The following is a description of a gene set: We have previously shown that rheumatoid factors (RF) produced by Fas-deficient autoimmune-prone mice typically bind autologous IgG2a with remarkably low affinity. Nevertheless, B cells representative of this RF population proliferate vigorously in response IgG2a/chromatin immune complexes through a mechanism dependent on the sequential engagement of the BCR and Toll-like receptor 9 (TLR9). To more precisely address the role of both receptors in this response, we analyzed the signaling pathways activated in AM14 B cells stimulated with these complexes. We found that the BCR not only serves to direct the chromatin complex to an internal compartment where it can engage TLR9 but also transmits a suboptimal signal that in combination with the signals emanating from TLR9 leads to NF-kappa-B activation and proliferation. Importantly, engagement of both receptors leads to the upregulation of a group of gene products, not induced by the BCR or TLR9 alone, that include IL-2. These data indicate that autoreactive B cells, stimulated by a combination of BCR and TLR9 ligands, acquire functional properties that may contribute to the activation of additional cells involved in the autoimmune disease process. Human Gene Set: GSE6674_UNSTIM_VS_ANTI_IGM_AND_CPG_STIM_BCELL_DN from publication Busconi L, Bauer JW, Tumang JR, Laws A, Perkins-Mesires K, Tabor AS, Lau C, Corley RB, Rothstein TL, Lund FE, Behrens TW, Marshak-Rothstein A (PMID 18025183) Genes down-regulated in B lymphocytes: control versus anti IgM and cell anti IgM and CpG oligodeoxynucleotide 1826. species: Homo sapiens, and this is the list of marker genes: ASB2, IL15RA, GEMIN4, EIF4A3, ABHD17C, DGKE, ARCN1, SLC37A3, MDFIC, DICER1, C19orf48P, SRSF6, HSD17B7, CD82, RIOX1, ZZZ3, MAPK8, KRI1, YDJC, POLR3D, USO1, C3orf18, MORC2, FNBP1, TXLNA, WDR43, ZDHHC21, GADD45G, CEBPZ, OTUD4, GNL3, MTAP, RRS1, LATS1, PPP2R1B, LARP4, BTG3, EXOSC1, BRIX1, URB2, HAPSTR1, IRF4, WDR74, ZDHHC13, RRP9, DET1, QSOX2, ALKBH1, RARS2, TGIF2, SELENOS (selenoprotein S), DDX54, WDR3, PSME3, GZMB, SLC20A1, MINDY3, ERN1, ADRM1, AFG2A, GCNT1, KIAA1191, NOP2, TFDP1, LRP12, LRP8, GTPBP4, NOC4L, MAFK, IPPK, PPA1 (NCBI Gene Id 5464), TWNK, C5orf22, MAT2A, DHX30, LDLR, RRN3, FMNL3, ENTR1, ELMO2, MACIR, HSPA9, PANK3, ARL4A, SIAH2, RBMXL1, PPP1R12A, NSUN2, AHCTF1, NAA25, ADSL, NDUFAF4, TSR1, OSM, LAP3, NAT10, ETV6, ATAD1, MRPL19, PIKFYVE, ZMYND19, MYC (NCBI Gene Id 731404), PDCD11 (programmed cell death 11), B3GALT6, TMEM68, TMEM39A, AEN, LCP2, INO80E (NCBI Gene Id 283899), KCNK5 (NCBI Gene Id 8645), ODC1, POLR3E, SYPL1, CDK6, PDCD1LG2, GTF2E1 (general transcription factor IIE subunit 1), UTP15, MAK16, UBA5, SLC4A7, TAMALIN, PICALM, NIP7, SEPTIN9, SOCS1, NOL9, DIS3, DIMT1, AFG2B, IL24, POLR1A, SLC37A1, TAFA3, USP31, MRPL17, PLEKHA3, XBP1, AKAP8, BDP1, SRM, TMEM185A, TRMT5, BAG5, TASOR2, SPRED1, THUMPD3, ATP8B2, FHL2, STRN3 (striatin 3), NMD3, PDP1, BYSL, LYPLA2, WSB2, DLST, CNBP, NHLRC1, SENP3, TARS1, SRSF2, PLK3, TUBA4A, UTP18, TEX2, TRMT10C, IL2RA, TNF, URB1, RASA2, PIM3, C7orf25, AGGF1, ATAD3A, NEDD9, CHCHD4, ZNF507, SRFBP1 (NCBI Gene Id 153443), UTP25, KCTD13, MARK3, MFSD2A, PPAN, RMDN3, DUSP4, PRMT5, ANKIB1, UTP4, EEF1E1, KANSL2, E2F3, DUS1L, ZCCHC2, EIF4G3, GMPPB, XPO5, BCLAF3, FAM185A (family with sequence similarity 185 member A), EIF1AY, G3BP2